Given this list of marker genes CASP10, TTC7A, TNFRSF1B, FAS (NCBI Gene Id 355), MSH6, NBN, CTLA4, MLH1, POLE, HAVCR2, CD28, FASLG, here is a description of the gene set: Human Gene Set: HP_T_CELL_LYMPHOMA species: Homo sapiens T-cell lymphoma A type of lymphoma that originates in T-cells.